The following is a description of a gene set: studied in species Mus musculus part of: Metabolism of fat-soluble vitamins electronically inferred by orthology from the curated human pathway This event has been computationally inferred from an event that has been demonstrated in another species.<p>The inference is based on the homology mapping from PANTHER. Briefly, reactions for which all involved PhysicalEntities (in input, output and catalyst) have a mapped orthologue/paralogue (for complexes at least 75% of components must have a mapping) are inferred to the other species. Reactome Pathway: Metabolism of vitamin K, and this is the list of marker genes: Ubiad1, Vkorc1l1, Vkorc1